The following is a description of a gene set: Human Gene Set: GSE3565_CTRL_VS_LPS_INJECTED_DUSP1_KO_SPLENOCYTES_DN species: Homo sapiens Genes down-regulated in spleen from DUSP1 knockout: control versus LPS. Activation of the Mitogen activated protein kinase (MAPK) cascade following Toll-like receptor (TLR) stimulation enables innate immune cells to rapidly activate cytokine gene expression. A balanced response to signals of infectious danger requires that cellular activation is transient. Here, we identify the MAPK phosphatase Dual specificity phosphatase-1 (DUSP1) as an essential endogenous regulator of the inflammatory response to LPS. DUSP1-deficient (DUSP1-/-) bone marrow derived macrophages showed selectively prolonged activation of p38 MAPK and increased cytokine production. Intraperitoneal challenge of DUSP1-/- mice with LPS caused increased lethality and overshooting production of IL-6 and TNF-alpha. Transcriptional profiling revealed that DUSP1 controls a significant fraction of LPS-induced genes, that includes IL-6 and IL-10 as well as the chemokines CCL3, CCL4 and CXCL2. In contrast, the expression of the important mediators of endotoxin lethality, IFN-gamma and IL-12, was not significantly altered by the absence of DUSP1. These data together demonstrate a specific regulatory role of DUSP1 in controlling a subset of LPS-induced genes that determines the outcome of endotoxin shock. from publication Hammer M, Mages J, Dietrich H, Servatius A, Howells N, Cato AC, Lang R (PMID 16380512), and this is the list of marker genes: FCHSD2, TSPAN13, ST8SIA1 (ST8 alpha-N-acetyl-neuraminide alpha-2,8-sialyltransferase 1), RPL36A, MDN1, PITPNM2, FOXO1, ST6GAL1, EIF4A1, KDM5A, ACTN1, CAPRIN1, LIPA, SYNCRIP, NSG2, SCMH1, UBE4B, TOX, TCP11L2, DAPL1, SELL, LRRC42, PLAC8, ITM2A, PRPS2, INPP4B, TTC3, DUSP10, NLK, CERS6 (NCBI Gene Id 253782), TANC1, ADCY6, S100Z, DKC1, IKZF2, ZEB1, JMJD1C, CD2AP, SRM, TCF7, MTHFD1L, INPP5F, IFNGR2, RAPGEF4, CNST, PDK1, ITGAE, DNMT3A, ABLIM1, TLR1, TBL1X (transducin beta like 1 X-linked), TET1, GGT1, PRKD2, PLEKHG2, CCR9, SH3PXD2A, FAM78A, CNR2, NEDD4L, TIMM9, ID3, RETREG1 (reticulophagy regulator 1), CSNK1G1, MGST2, XKRX, BICDL1, TOP2B, FAM3C (NCBI Gene Id 10447), WDR26, MTSS1, FANCC, NPC2 (NCBI Gene Id 10577), ADCK5, RAPGEF6, N4BP2, GRIFIN, DAG1, SIDT1, HDAC4, TRIM25, RPL28, TMEM108, CXXC5, CEP295NL, ART4, EPHX1, ANKRD55, TRIB2, LBH, ALS2CL, EEF2, FILIP1L, EGR2, TRERF1, MAP4K4, DPH5, ZYG11B, RNF114, PELI1, TIMP2, ACSF2, ABCG1, PLEKHO1, SNRK, PACSIN1, RPF2, PIK3IP1, EXT1, SESN1 (NCBI Gene Id 27244), RALGPS2, IKZF1, CLASP2, PATJ, CCR7, RAB3IP, USP28, RRAS2, MBD3, DGKA, ETV3, AMPD1, EIF4B, CCT5, TREML2, CHST15, GTF2I, DUSP6, MAP4K2, IKBKE (NCBI Gene Id 9641), SREBF2, POLE2, GRIA3, EEF1B2, SMC4, LEF1, TFRC, KLHDC2, STT3B, ENG, SIPA1L1 (NCBI Gene Id 283567), RHOH, MARS2, ARHGAP9, GRK6, CCDC28B, AKAP13, ADD3, RPL18, IRS2, GPR146, SATB1, NRIP1, GRAMD1A, WDR43, MYB, GSTT2, RPS6KA1, RPS26, TMEM131, MPP1, SLC16A5, IDH2, PIK3C2A, TMIE, CARMIL2, MYC, SSBP2, IFT80, LTB, PCBP1